Given this list of marker genes SMAD4, TACR2, LEP, OPRK1 (NCBI Gene Id 4986), CRH, FOXL2, here is a description of the gene set: Human Gene Set: GOBP_REGULATION_OF_LUTEINIZING_HORMONE_SECRETION species: Homo sapiens Any process that modulates the frequency, rate or extent of the regulated release of luteinizing hormone.